The following is a description of a gene set: Abnormality of the vertebral endplates Human Gene Set: HP_ABNORMALITY_OF_THE_VERTEBRAL_ENDPLATES Any abnormality of the vertebral end plates, which are the top and bottom portions of the vertebral bodies that interface with the vertebral disks. studied in species Homo sapiens, and this is the list of marker genes: EIF2AK3, B3GALT6, GNPAT, CLCN7, KIF22, POLR3A, DYM, ZFX, SLC29A3, ZBTB20, TCIRG1, PAPSS2, FN1, NANS, LRRK1, PDE4D, RNU4ATAC (NCBI Gene Id 57788), GORAB, SOST, DMP1, SLC39A13 (solute carrier family 39 member 13), EXOC6B, COMP, COL9A3, COL9A2, ACP5, MMP13, COG4, CHST3, CCN6, ENPP1, TRAPPC2, TONSL, SLC10A7, COL10A1, IDH1, COL9A1, TNFRSF11A, COL2A1